Given this list of marker genes Rbbp7, Ercc3, Gtf2h2, Polr1h, Polr2k, Polr2f, Polr1g, Polr1e, Polr2e, Mta2, Mapk3, Ercc2, Gtf2h4, Rbbp4, Ercc6, Mta1, Mbd3, Polr2l, Ccnh, Polr1c, Taf1d, Tbp, here is a description of the gene set: Reactome Pathway: RNA Polymerase I Promoter Clearance This event has been computationally inferred from an event that has been demonstrated in another species.<p>The inference is based on the homology mapping from PANTHER. Briefly, reactions for which all involved PhysicalEntities (in input, output and catalyst) have a mapped orthologue/paralogue (for complexes at least 75% of components must have a mapping) are inferred to the other species. studied in species Mus musculus part of: RNA Polymerase I Transcription electronically inferred by orthology from the curated human pathway